The following is a description of a gene set: studied in species Homo sapiens Human Gene Set: TACAATC_MIR508 Genes having at least one occurence of the motif TACAATC in their 3' untranslated region. The motif represents putative target (that is, seed match) of human mature miRNA hsa-miR-508 (v7.1 miRBase)., and this is the list of marker genes: CLASP1, ZBTB33, ARPP19, EIF3J, FGF7P3, HTR2C, HMGA2, PHTF2, SUB1, PTPN9, VNN3P (NCBI Gene Id 55350), FGF7, SMG1, GLCE, LMO3, GRM8, BDNF (NCBI Gene Id 627), RNF103, RAD23B, CTDSPL2, RSBN1, SETD7, SREK1, MITF, HBP1, RANBP9, TFAP2B, SORCS1, CPNE2, HOXA1, LAMTOR3, LHX8 (NCBI Gene Id 431707), GRIA2, CENPP, MAPK1IP1L, ABLIM3, NDST1, SEPTIN7, ADNP, RAPH1, ARL4C, PURB, PPP4R3A, HMGN1, KLF4, AGO2 (NCBI Gene Id 286109, argonaute RISC catalytic component 2), NONO, ZBTB44, PHYHIPL, SRSF1, ARHGEF12, MSTN, NUMB, DNAJB1, BMI1, PIKFYVE, DHDDS, TNPO1, VAPA, NLK, RHOQ, FGF7P6, FCHSD2, NR4A3, SATB1, TAB3, UBP1